The following is a description of a gene set: species: Homo sapiens Any process that activates or increases the frequency, rate or extent of skeletal muscle cell differentiation. Human Gene Set: GOBP_POSITIVE_REGULATION_OF_SKELETAL_MUSCLE_CELL_DIFFERENTIATION, and this is the list of marker genes: GPC1, MCUB, MEF2C, KAT8, MIR1-1, CYP26B1 (NCBI Gene Id 56603), BMAL1, RBM24, TBX1